Given this list of marker genes Synpr, Slc30a1, Fmn1, Mog, Suclg2, Angptl2 (angiopoietin-like 2), Serpinb11 (NCBI Gene Id 98515), Irf2 (NCBI Gene Id 16363), Tmem196, Ly6g6c, Tcf12, Rab2a, Pcnp, Sptssa, Pik3r5, Bbip1, Gnaz, Birc6, Nxph1, Vamp5, Mapk10, Rock1, Gm14137 (NCBI Gene Id 639597), Lin28b, Selenop, Arhgap30, Neto1, Tmem154, Clec2l, Foxo1, Grik2, 1700029F12Rik, Vip, Prkca, Trappc3, AA414768, Enah, Hnrnpf, Il1rap, Intu, Igf1, Cntfr, Prelid3b, Gm4724, Il12b, Nhsl3, Gcm2, Zfhx3, Rab7, Zfp352, H2-Q4, Cxxc4, Dmtf1l, Sh3rf3, Ift57, Lhx3, Pde3a, Chst1, Lhfpl4, Scn8a, Adamts5 (ADAM metallopeptidase with thrombospondin type 1 motif 5), Aasdhppt, Alcam, Eif4e3, Ap1g1, Wapl, Sh3rf2, Drd5, Kcnj3, Ppp2r3d, Osbpl8, Nphs1, Gm14434, Sestd1, Isca1, Zbtb6, Gngt2, Yipf5, Itpr2, Med19, Stil, Patl1, Vsnl1, Sp4, Npr2, Hook2, Prelid2, Stk3, Tbl1xr1, Kcnq5, Zfp37, Zfp598, Pds5b, Hoxa5, Krtap9-21, Gm14308, Atp8b1 (NCBI Gene Id 54670), Fat2, Plppr1, Dhx15, Rims2 (NCBI Gene Id 72660), Pigk, here is a description of the gene set: from publication Chen Y, Wang X (PMID 31504780) Mouse Gene Set: MIR_6979_3P studied in species Mus musculus Genes predicted to be targets of miRBase v22 microRNA mmu_miR_6979_3p in miRDB v6.0 with MirTarget v4 prediction scores > 80 (high confidence targets).